The following is a description of a gene set: Human Gene Set: GSE26351_UNSTIM_VS_BMP_PATHWAY_STIM_HEMATOPOIETIC_PROGENITORS_DN species: Homo sapiens Analysis of mobilized peripheral blood CD34+ cells from a healthy volunteer under erythroid differentiation conditions with and without stimulation to the BMP or Wnt signaling pathways. For erythroid differentiation, expanded CD34+ cells were placed in Stemspan SFEM medium supplemented with 2% pen/strep, 20ng/ml SCF, 1U/ml Epo, 5ng/ml IL3, 2uM dexamethasone, and 1uM beta-estradiol. Arrays were performed 2 hours after addition of cytokines. For signaling pathway stimulation, cells were exposed to 0.5uM BIO (a GSK3 inhibitor) for Wnt pathway activation, 25ng/ml rhBMP4 for BMP pathway activation, or vehicle control for 2 hours. Three biological replicates were performed per treatment group. We used microarrays to detail the global program of gene expression changes after Wnt or BMP pathway stimulation in human CD34+ hematopoietic progenitors under erythroid differentiation conditions. Genes down-regulated in CD34+ cells: control versus stimulated by BMP4. from publication Trompouki E, Bowman TV, Lawton LN, Fan ZP, Wu DC, DiBiase A, Martin CS, Cech JN, Sessa AK, Leblanc JL, Li P, Durand EM, Mosimann C, Heffner GC, Daley GQ, Paulson RF, Young RA, Zon LI (PMID 22036566), and this is the list of marker genes: RNF213, CACNG6, PALM, RPL7, GNB2, DNPH1, HM13, UCKL1, SV2B, ZC3H3, RPLP0, TOMM70, BTNL2, TPTE, TOMM6, HELLS, TREX1, FGD6, HMGB2, ATP6V0E1, VILL, ELOVL6, FGD2, SPOP, TAS2R4, ATXN2L, DYNLRB1, GPR176, CCDC107, HTT, CYP21A1P, PPT2, NDUFA4, RELL2, DYNLL2, COMMD5, ATF6B, ZBTB42, AQP6, NECAB2, PPIA, GJB2, ADGRB2, RPL26, AADAT, KDF1, IFITM5, CCDC184, COL9A1, WNT16, BAIAP2, CLNK, BBLN, TULP1, EPS8, SAMHD1, KCTD4, THEM6, THSD7B, FLNB, RTKN, TEX9, MST1, HMGB1, SETDB2, NTNG1, FSIP1, CTDP1, TRAF1, ADAMTS2, RPS9, CMTM5, TFF2, E2F4 (NCBI Gene Id 1874), ZNF22, ATP5PF, TBC1D13, CEP55, DEUP1, OTOG, ENTPD2, CALY, PAXBP1, RINL, MICOS10, SLC12A3, HLCS (NCBI Gene Id 3141), CORO1A, RPH3A, CCDC191, PAK5, RNF167, CNTNAP2, RPS3, HSDL2 (hydroxysteroid dehydrogenase like 2), PPP1CA, PRKAR2B, MPZL2, GPI, SMCO4, SUPT5H, TMEM116, UNC93B1, PECAM1, KDM7A, PIK3CB, UQCRC1, CD2AP, ELAC2, LSM4 (LSM4 homolog, U6 small nuclear RNA and mRNA degradation associated), C16orf96, SLCO5A1, ADAMTS7, TP53RK, ERLIN1, GATD1, FAM86B2, SH3BGRL, ARHGEF28, CCNE2 (NCBI Gene Id 9134), CKMT1B, RNF126, SGCA, LRRC1 (leucine rich repeat containing 1), ENTREP3, CBX5, MASTL, RAB38, IL3RA, RNF123, RAB4B, STAT5A, STX17, NDUFAF8, DAP, MYL6 (NCBI Gene Id 4637), CEP128, YWHAQ, CHRNA4, SBF1, IHH, TTC5, ATP5MC3 (ATP synthase membrane subunit c locus 3), PCYT1B, TDRD5, VPS36, ZSWIM8, SDHAF2, PKMYT1, GCGR, COX14, FDXR, ZNF414, AIF1L, MPPE1, TMEM94, SRSF2, MPZL3, MOB3B, ANAPC11, PEX5L, ASAP2, LAD1 (NCBI Gene Id 3898), TAPBPL, PAPSS2, MAP1A, DHRSX, BEX3, UQCRQ, ARF3, ADAR, ENPP5, CCDC103, XRN2 (5'-3' exoribonuclease 2), IFRD2, PTPN18, ALOXE3, GNAI3, CCAR2, PARP4, TIAM1, PRDX6, DDX55, SLC16A14, CLEC1A (NCBI Gene Id 51267), RPS14, SMN1, ALDH3A1, AVIL, FLT1, ERCC6L, UBE2S, PPM1J, PCP2, AUTS2, RPRML, ERICH3, PUS10, KAZN